The following is a description of a gene set: With increasing age, the ability of the immune system to protect against recurring infections or to control chronic infections erodes. The objective of the current study was to identify gene expression signatures in elderly CD4 T cell responses from publication Yu M, Li G, Lee WW, Yuan M, Cui D, Weyand CM, Goronzy JJ (PMID 22434910) studied in species Homo sapiens Genes down-regulated in comparison of memory CD4 T cells from young donors treated with TSST at 72 h versus those from old donors treated with TSST at 72 h. Human Gene Set: GSE36476_YOUNG_VS_OLD_DONOR_MEMORY_CD4_TCELL_72H_TSST_ACT_DN, and this is the list of marker genes: AANAT, CCNG1, BTN3A1, NPEPPSP1, RFX5, MAGEH1, RPS14 (ribosomal protein S14), ING4, SH2B3, AMIGO2, MANBA, SIRT4, CD200, PRKCB, NELL2, PARP4, NSA2, EIF3H, FHIT, IL21R, TNFRSF9, DCP1A, CYP39A1, EML2 (EMAP like 2), LIN7B, HEBP2, CAMK4, NFU1, RBM47, MEGF9, ACTR1B, DUSP1, HCP5, ADARB1, ZNF816, VPS35, SLC11A2, SP140L, PIGL, IFI30, BCL6, IL5, ZNF41, SPOP, PRR5L, ENTR1, DHRS3, MAP1LC3B, NR3C1, PATJ, HLA-DPA1, PARP3, RBM5, SIK2, CSF1, PCMTD2, DYNLT3, SPG11, AFF4, TSPAN14, ZNF281, BSCL2, CX3CR1, GPR39, CD70, CPT2, HBP1, METTL22, TRIM22, LIPT1 (lipoyltransferase 1), ZNF345, NDUFAF7, ZNF248, AGO1, CSF2RA, PTGIR, TMEM243 (transmembrane protein 243), TTN, RMC1, NAT9, CLK4, GLCE, EXT1, PDZD8, CXCL13, BBS1, POMZP3 (NCBI Gene Id 96438), ATP8A1, CWC25, PDCD2, ZNF16, ARGLU1, ANKRD27, IL9, PNLIP, DAPK2, MMP20, MXI1, ST8SIA1, MYLIP, PRPF40A, PTCH1, RGS16, HLA-DMA, TFG, GOLGA8A, TGIF1 (NCBI Gene Id 91941), SARAF, PRICKLE3, FAM13A, OGG1, VWA8, TREM2, GARRE1, PLEKHA1, ZNF37BP, N4BP2L1, CTSO, PNPLA4, RBPJ, CD82, KIF3B, CAPRIN2, BTD, MTERF4, STX11, BPHL, TCEA2, PLEK, PNPLA2, ZBED5, BNIP3L (NCBI Gene Id 9257), LRRC37A2, H2BC7, FOXN3, BCAS3 (BCAS3 microtubule associated cell migration factor), TRIM38, MAML1 (NCBI Gene Id 9794), SART3, OXLD1, PNISR, POGLUT1, ABCA5, SYT11, ATXN2, AOAH, CSF2RB, FYB1, NR4A2, APMAP, TIAM1, PIK3IP1 (NCBI Gene Id 113791), MTCP1, SCML1, GSDME, ECHDC2, N4BP2L2, FRG1JP, H2AC18, SPRED2, HLF, ACP5, PCGF3, NTRK1, ITIH4, HCK, TRIP10, CSAD, TRAPPC13, ZSCAN32, PRKAB1, AFTPH, ZNF266, PDE6B, TRIM33, GNRH1, CCR7, EPB41L3 (erythrocyte membrane protein band 4.1 like 3), CAB39L, CRLF2, STX16, RSAD1, SEMA3E, DRAM1, MARCHF6, ZFYVE21, CNOT4, AASS, NSUN5P2, PDE3B, CBY1, NLK, GPR137B, CD302, B3GALT2, ZNF767P, SUGP2, SYNJ1